Given this list of marker genes MARCHF10, SH3D19, NRSN1, MFAP2, SPO11, DPEP3, CRYGA, TAL1, BRDT, CCDC83 (NCBI Gene Id 220047), RASGRP3, LRRC8E, PRSS44P, KRT27, BARHL1, PCDHB5, SLC26A5, PRM1, ADAM1B, PDHA2, PCDHA8, CYP4X1 (cytochrome P450 family 4 subfamily X member 1), TSSK2, GLRA1, LYPD4, TEX101, ADCYAP1, TUBA3D, TEX13B, IL12A, PCDHA7, LYPD2 (NCBI Gene Id 137797), CLIC5, PCDHB12, CCDC110, PCDHB10, JPH2, CYP4F22, SLITRK2, EDAR, CNGA4, IQCA1L, MYCN, NOS1 (nitric oxide synthase 1), DMRTC2, DNAJB8, COL8A1, TEKTIP1, OR2F1, BAHCC1, DIRAS1, KCND3, ABCC9, KRT26, PLA2G4E, SCGN, PCDHB18P, SPAG8, XYLT2, AHRR, PCDHB14, RTL8B, FSCN2, ASZ1, RCVRN, SST, GIGYF1, MGAT4D, GOLGA7B, SPATA22, FTL, KIAA1755, PCDHA9 (NCBI Gene Id 9752), NT5DC2, POMC, PIWIL1, SPIRE1, DCC, NAP1L5, SLC45A1, FGF6, GRID2IP, KCNH6, SSTR2, TNNI3, PCDHB15, here is a description of the gene set: Human Gene Set: MIKKELSEN_IPS_HCP_WITH_H3_UNMETHYLATED from publication Mikkelsen TS, Hanna J, Zhang X, Ku M, Wernig M, Schorderet P, Bernstein BE, Jaenisch R, Lander ES, Meissner A (PMID 18509334) Genes with high-CpG-density promoters (HCP) without H3 methylation marks at either H3K4 or H3K27 in MCV8.1 cells (induced pluripotent cells, iPS). Somatic cells can be reprogrammed to a pluripotent state through the ectopic expression of defined transcription factors. Understanding the mechanism and kinetics of this transformation may shed light on the nature of developmental potency and suggest strategies with improved efficiency or safety. Here we report an integrative genomic analysis of reprogramming of mouse fibroblasts and B lymphocytes. Lineage-committed cells show a complex response to the ectopic expression involving induction of genes downstream of individual reprogramming factors. Fully reprogrammed cells show gene expression and epigenetic states that are highly similar to embryonic stem cells. In contrast, stable partially reprogrammed cell lines show reactivation of a distinctive subset of stem-cell-related genes, incomplete repression of lineage-specifying transcription factors, and DNA hypermethylation at pluripotency-related loci. These observations suggest that some cells may become trapped in partially reprogrammed states owing to incomplete repression of transcription factors, and that DNA de-methylation is an inefficient step in the transition to pluripotency. We demonstrate that RNA inhibition of transcription factors can facilitate reprogramming, and that treatment with DNA methyltransferase inhibitors can improve the overall efficiency of the reprogramming process. studied in species Mus musculus